Given this list of marker genes Insig2, Atg9b, Tmem38b, Dchs1, Msx1, Smad1, Rflna, Ext2, Atf2, Tfap2a, Ski, Dlx5 (NCBI Gene Id 13395), Sparc, Cfh, Thbs1, Bbln, Sp5, Bglap3, Fbn1, Tgfb1, Megf8, Hsd17b1, Bmncr, Sik3, Papss2, Col3a1, Itgb6, Galnt3, Sbds, Inppl1, Cyp26b1, Col27a1, Anxa2 (annexin A2), Ogn, Slc10a7, Gnas, Bpnt2, Por, Ripply2, Lepr, Mmp16, Cldn18, Setdb1, Comp, Nab2, Tyrobp, Tnn (NCBI Gene Id 329278), Opa3, Akap13, Bnc2, Glg1, Tnfsf11, Kat2a, Spns2 (NCBI Gene Id 216892), Timp3, Ddr2, Ccdc154, Fbxw7, Lrp5, Osr2, Nsd2, Ptger4, Ltf, Ift80, Hoxa11 (homeobox A11), Rflnb, Stc1, Map2k6, Sulf1, Src, Fat4, Tgfbr2, Tifab, Matn1, Mmp14, Lipa, Pls3, Adamts7, Tulp3, Carm1, Siglec15, Ankrd11, Cbs, Ctc1, Tgm2, Rpl13-ps6, Scube2, Optc, Trim45, Smpd3, Mbtps2, Col6a1, Trpv4, Mef2d, Lrp6, Kdr, Rara, Ebp, Srd5a2, Pax1, Ryr1 (NCBI Gene Id 20190), Chad, Cr2, Mir188, Has2, Pafah1b1, Tapt1, Hottip, Ccn4, Actn3, Ifitm5, Col13a1, Phospho1, Rgn, Ppib, Pappa2, Ostn, Lep (leptin), Bgn, Cer1, Notch2, Fancb, Msx2, Gli3, Serpinh1, Alpl, Ninj1, Epyc, Col1a1, Nab1, Enpp1, Pex7, Pthlh, Wnt1, Col9a1, Bmp4, Ptprc, Nfix, Ext1, Axin2, Mmp13, Cited2, Eng, Idua, Cst5, Dhrs3, Prpsap2, Twist1, Lrrc17, Pth, Pdgfc, Asxl1, Zmpste24, Npr2, Bglap, Smad9, Sox9, Cdx1, Fbln5 (fibulin 5), Lrrk1, Bmp6, Bmpr2, Evc (NCBI Gene Id 59056), Trp53, Rpl13, Tmem107, Gja1, Dmd, Pdgfa, Bbx, Slc9b2, Ano6, Igf1 (NCBI Gene Id 320499), Grem1, Thbs3, Mir2861, Bglap2, Cadm1, Sh3pxd2b, Zbtb16, Foxn3, Bmpr1b, Mef2c, Acp5, Sulf2, Adamts12, Dspp, Fgf8, Hoxb4, Foxc1, Tmem119, Hspg2, Rhoa, Snx10, Rarb, Fgf4, Mcph1, Myoc, Fosl2, Slc38a10, Ecm1, T, Ripply1, Shox2, Gpr68 (NCBI Gene Id 238377), Ift172, Phex, Map3k7, Col2a1, P3h1, Fam20c, Large1, Frem1, Mapk14, Col10a1, Trip11, Tjp2, Bmp2, Ltbp3, Hoxd11 (NCBI Gene Id 319663), Fgfr3, Ghrl, Sema4d, Dym, Ttc9, Ihh, Rarg, Csgalnact1, Sfrp4, Nppc, Amer1, Mapk11, Smad5, Xylt1, Lox, Runx2, Neurog1, Atp6ap1, Scx, Vkorc1, Rab23, Poc1a, Chsy1, Fgf18, Plxnb1, Insig1, Ggcx, Miga2 (NCBI Gene Id 99073), Ranbp3l, Atg9a, Foxp1, Pitx2, Fgfr2, Notum, Asxl2, Gas5, here is a description of the gene set: The process whose specific outcome is the progression of bone over time, from its formation to the mature structure. Bone is the hard skeletal connective tissue consisting of both mineral and cellular components. Mouse Gene Set: GOBP_BONE_DEVELOPMENT species: Mus musculus